The following is a description of a gene set: A protein complex that contains one or more cysteine-type endopeptidases (also called caspases), which give the complex a peptidase activity with specificity for the hydrolysis of aspartyl bonds. These complexes may be involved e.g. in apoptotic or inflammation processes. Human Gene Set: GOCC_CASPASE_COMPLEX species: Homo sapiens, and this is the list of marker genes: PIGS, PIGU, CAPN1, CAPNS1, PIGK (NCBI Gene Id 10026), PIGT, CASP9 (NCBI Gene Id 842), CAPNS2, GPAA1, CAPN2